The following is a description of a gene set: studied in species Mus musculus Binding to a nuclear receptor protein. Nuclear receptor proteins are DNA-binding transcription factors which are regulated by binding to a ligand. Mouse Gene Set: GOMF_NUCLEAR_RECEPTOR_BINDING, and this is the list of marker genes: Wipi1, Lrif1, Foxp1 (forkhead box P1), Tcf7l2 (NCBI Gene Id 21416), Nup62, Mecr, Parp1, Ddx5, Dnmt1, Rarb, Nr1h4, Sumo2, Pik3r1, Dnaaf4, Rnf6, Stat3, Cebpb, Ncoa6, Nsd1, Foxl2, Bud31, C1d, Hsd17b10, Lcor, Trip12, Brd8, Med13, Ppargc1b, Trerf1, Vdr, Ncoa2, Ep300, Snw1, Nrbf2, Fus, Gtf2h1 (NCBI Gene Id 97364), Prpf6, Trip4, Per2, Stat5b, Ncor1, Tcf21, Slc30a9, Hr, Hmga1, Foxh1, Psmc3ip, Ncoa1, Kdm3a, Smarcd3, Uimc1, Pparg, Lef1, Dcaf1, Nr0b2, Ipo13, Sra1, Trim68, Mms19, Strn, Ppid, Ncoa3, Ppargc1a, Thrap3 (NCBI Gene Id 320018), Actn4, Trim24, Med24, Taf11, Ar, Med1, Nr4a1, Src, Pramel13, Esr1, Padi2, Prmt2, Kdm4c, Rxra, Dcaf13, Smarca4, Flt3, Smad3, Med25, Fkbp4, Nkx3-1, Lrp2, Taf7, Kdm1a (NCBI Gene Id 99982), Rnf4, Prox1, Med4, Rxrb, Nrip1, Nr0b1 (nuclear receptor subfamily 0, group B, member 1), Lats1 (large tumor suppressor), Arrb1, Park7, Nr4a2, Nr1h3, Arid5a, Myod1, Isl1, Jup (junction plakoglobin), Taf10, Pias2, Foxp2, Zfp366 (zinc finger protein 366), Tacc1, Ctnnb1, Uba3, Hmga1b (NCBI Gene Id 15362), Kdm5d, Smarce1 (SWI/SNF related, matrix associated, actin dependent regulator of chromatin, subfamily e, member 1), Pcna, Ncoa7, Pkn1, Ets2 (E26 avian leukemia oncogene 2, 3' domain), Cry1, Tacc2, Nr1h2, Jund, Nr4a3, Hif1a, Stat1, Zbtb7a, Tob2, Crx, Gtf2b, Wbp2, Rarg, Arid1a, Daxx, Pagr1a, Sirt1, Tgfb1i1, Rnf14, Cry2, Asxl1, Asah1 (N-acylsphingosine amidohydrolase 1), Ccdc62, Tmf1, Med12, Cnot1, Ctbp2, Med16, Ddx54 (NCBI Gene Id 71990), Tada3 (NCBI Gene Id 68474), Ywhah, Bcas3, Med17, Calr, Med30, Nr1i2, Prkcb, Taf1, Srarp, Ncor2, Grm1